Given this list of marker genes Tmprss11c, Tmprss6, Adgrv1, Casp8, Nlrp1a, Lgmn, Capn1, Shh, Ihh, Capn8, Casp12, Nlrp1b, Capn3, Capn7, Dhh, here is a description of the gene set: Mouse Gene Set: GOBP_SELF_PROTEOLYSIS studied in species Mus musculus The hydrolysis of proteins into smaller polypeptides and/or amino acids by cleavage of their own peptide bonds.